Given this list of marker genes Slx4, Pot1b, Terf2, Recql4, Wrn (NCBI Gene Id 22427), Rtel1, Pot1a, Terf1, Blm, here is a description of the gene set: The telomere maintenance process in which telomeric loops are disassembled to permit efficient telomere replication. species: Mus musculus Mouse Gene Set: GOBP_TELOMERIC_LOOP_DISASSEMBLY